Given this list of marker genes Ulk2, Dpy19l3, Tex24, Acacb, Srebf1, Atox1, here is a description of the gene set: studied in species Mus musculus We generated a line of mice in which sterol regulatory element binding protein 1a (SREBP-1a) was specifically inactivated by insertional mutagenesis. Homozygous mutant mice were completely viable despite expressing SREBP-1a mRNA below 5% of normal, and there were minimal effects on expression of either SREBP-1c or -2. Microarray expression studies in liver, where SREBP-1a mRNA is 1/10 the level of the highly similar SREBP-1c, demonstrated that only a few genes were affected. The only downregulated genes directly linked to lipid metabolism were Srebf1 (which encodes SREBP-1) and Acacb (which encodes acetyl coenzyme A carboxylase 2, a critical regulator of fatty acyl-CoA partitioning between cytosol and mitochondria). ACC2 regulation is particularly important during food restriction. Similar to Acacb knockout mice, SREBP-1a-deficient mice have lower hepatic triglycerides and higher serum ketones during fasting than wild-type mice. SREBP-1a and -1c have identical DNA binding and dimerization domains; thus, the failure of the more abundant SREBP-1c to substitute for activating hepatic ACC2 must relate to more efficient recruitment of transcriptional coactivators to the more potent SREBP-1a activation domain. Our chromatin immunoprecipitation results support this hypothesis. Genes differentially expressed in liver tissue upon knockout of the 1a isoform of SREBF1. from publication Im SS, Hammond LE, Yousef L, Nugas-Selby C, Shin DJ, Seo YK, Fong LG, Young SG, Osborne TF (PMID 19564420) Mouse Gene Set: IM_SREBF1A_TARGETS